Given this list of marker genes Hes1, Hes5, Wt1, Bmp4, Lhx1, Hey1, Pax8, here is a description of the gene set: Mouse Gene Set: GOBP_COMMA_SHAPED_BODY_MORPHOGENESIS The process in which the comma-shaped body is generated and organized. The comma-shaped body is the precursor structure to the S-shaped body that contributes to the morphogenesis of the nephron. studied in species Mus musculus